Given this list of marker genes MED12, ERI1, CSGALNACT1 (NCBI Gene Id 55790), FOXP2, CHSY1 (chondroitin sulfate synthase 1), PIK3CD, HNRNPR, KNSTRN, IFT140 (NCBI Gene Id 9742), here is a description of the gene set: Human Gene Set: HP_CLINODACTYLY_OF_THE_2ND_FINGER Clinodactyly of the 2nd finger studied in species Homo sapiens